The following is a description of a gene set: Catalysis of the reaction: ATP + H2O = ADP + phosphate, in the presence of single-stranded DNA; drives the unwinding of a DNA helix. Human Gene Set: GOMF_SINGLE_STRANDED_DNA_HELICASE_ACTIVITY species: Homo sapiens, and this is the list of marker genes: RFC2, MCM7, RFC4, MCM2, HELB, MCM5, HELQ (helicase, POLQ like), CHTF18, DHX9, MCM3, MCM8, CHTF8, DSCC1, MCM4, POLQ, MCM9, PIF1 (NCBI Gene Id 89987), DNA2, RFC5, RFC3, WRNIP1, RAD51, MCM6